The following is a description of a gene set: studied in species Homo sapiens Protein complex that mediates editing of the mRNA encoding apolipoprotein B; catalyzes the deamination of C to U (residue 6666 in the human mRNA). Contains a catalytic subunit, APOBEC-1, and other proteins (e.g. human ASP; rat ASP and KSRP). Human Gene Set: GOCC_APOLIPOPROTEIN_B_MRNA_EDITING_ENZYME_COMPLEX, and this is the list of marker genes: APOBEC3F, APOBEC1, RBM47, APOBEC3G, A1CF